Given this list of marker genes CLDN15, CLDN2, CLDN4, CLDN17, CLDN19, CLDN10, CLDN16, here is a description of the gene set: Human Gene Set: GOBP_PARACELLULAR_TRANSPORT studied in species Homo sapiens The directed movement of substance through the space in between adjacent cells, rather than through the cells themselves.